Given this list of marker genes Golph3, Fut9, Ccl21a, Ccl21f, Itga4, Vcam1, Cxcl12, Pawr, Selplg, Gcnt1, Tnf, Capn1, Itgb1, Selp, Ccl21d, Madcam1, Jam2, Elane, Ccl21b, Ccr2, Ptafr, Ext1, Gp1ba, Sell, Spn, Ccl28, Chst2, Add2, Fut4, St3gal4, Ccl25, Sele, Rock1, Cx3cr1, Ccl21e (C-C motif chemokine ligand 21E), Chst4, Podxl2, Fut7, Lep, Itgb7, here is a description of the gene set: Mouse Gene Set: GOBP_LEUKOCYTE_TETHERING_OR_ROLLING Transient adhesive interactions between leukocytes and endothelial cells lining blood vessels. Carbohydrates on circulating leukocytes bind selectins on the vessel wall causing the leukocytes to slow down and roll along the inner surface of the vessel wall. During this rolling motion, transitory bonds are formed and broken between selectins and their ligands. Typically the first step in cellular extravasation (the movement of leukocytes out of the circulatory system, towards the site of tissue damage or infection). studied in species Mus musculus